The following is a description of a gene set: Mouse Gene Set: GOBP_CELLULAR_RESPONSE_TO_HORMONE_STIMULUS studied in species Mus musculus Any process that results in a change in state or activity of a cell (in terms of movement, secretion, enzyme production, gene expression, etc.) as a result of a hormone stimulus., and this is the list of marker genes: Usp26, Flt1, Crhbp, Sorl1, Hmgcs2, Ghr, Vps54, Appl2, Nodal, Prcp, Ufm1, Lbh, Opa1, Pias2, Ctsh, Pparg (peroxisome proliferator activated receptor gamma), Or51e2, Apc, Anxa5, Gpld1, Scnn1b, Avpr2, Tns2, Pagr1a, Il1b, Cry2, Mettl21c, Mir126a, Pde4d, Max, Kank1, Vdr, Ass1, Cpeb2 (cytoplasmic polyadenylation element binding protein 2), Hras, Pcsk9, Leprotl1, Tfpi, Rxra (NCBI Gene Id 78740), Bmi1, Nucb2, Cyp26b1, Nck1, Slc27a4, Slc2a4, Prkaa1, Kmt2e, Ywhah, Kdm5d, Uso1, Foxh1, Grb14, Rab31 (NCBI Gene Id 67353), Rac1, Anxa1, Zfp592, Rhoa, Ntrk2, Tnfsf4, Dhrs3 (dehydrogenase/reductase 3), Sfrp1 (secreted frizzled-related protein 1), Adcy8, Kdm3a, Abhd2, Nedd4, Sos2, Akr1c19, Nr1d2, Cnot3, Irs2, Scgb2a2, Nr1h2, Flt3, Hnrnpk, Agtr2, Rab8a, Igf1, Epha8, Clock, Fgf23, Ucp1, Mdm2, Mst1r, Gpt, Crh, Mt3, Pck1, Gstp1, Ren1, Ntrk1, Trarg1, Rela, Kbtbd2, Park7, Tcf21, Oxtr (NCBI Gene Id 18430), Mir155, Ar (NCBI Gene Id 11835), Cnot1, Kdm4c, Bglap (bone gamma carboxyglutamate protein), Hcrtr2, Sstr5, Ddit4, Gdf15, Ghsr, Ctnnb1, Adra2a, Lonp1, C2cd5, Csf1r, Rarb, Fgfr2, Mef2c (myocyte enhancer factor 2C), Per1, Nono, Mbd5, Blvra, Calr, Edn1, Naip2, Pik3r3, Ugt1a6a, Nucks1, C1qtnf12, Nr1h3, Cdk2, Rxrg, Sirt1, Epha4, Zfp36l1, Npas4, Kdm6a, Insig2, Bglap2, Fam114a1, Foxo3, Mir18, Fbxw8, Adipor2, Cga, Slc26a6, Akt3, Usf1, Mapk1, Mzb1, Ceacam1, Nfkb1, Ggcx, Aifm1, Zfp106, Phb2, Erfe, Gcg, Ywhag, Rxrb, Thra, Srarp, Rnf6, Cacna1a, Agtrap, Smarcc1, Fshr, Uri1, Rangap1, Atp1a2, Zfp764l1, Leprot, Ffar3, Prlr, Akr1c13, Mstn, Vamp2, Ppargc1a, Erbb2, Rxfp1, Trim24, Rwdd1, Gata4, Hdac9, Prl, Nr5a2, Ramp1, Cfl1, P2ry4, Ptprv, Brca1, Shoc2 (Shoc2, leucine rich repeat scaffold protein), Reg1, Mup4, Map2k1, Prkcd, Gata6, Glp2r, Myod1, Fam107a, Blvrb, Ppp3ca (NCBI Gene Id 99901), Trerf1, Rhoq, Lats2, Cuzd1, Agt, Sorbs1, Ucp3, Echdc3, Agrp, Pou4f2, Ang2, Ctsb, Vps11, Pax8, Foxc2, Sox10, Mir451a, Fer, Got1, Tnf, Nsmf, Notch1, Eef2k, Tyk2, Eif4ebp2, Pik3r1, Ros1, Cyfip1, Hdac6, Il18 (interleukin 18), Smyd3, Nr4a3, Slit3, Arid5a, Mup11 (major urinary protein 11), Ide, Epha2, Sp1, Zbtb7b, Ogt, Ptpra, Lmo3, Ptk2, Sstr1, Syap1 (synapse associated protein 1), Sstr4, Ret, Crhr1, Ramp3, Ctbp2, Aldh1a2, Mir708, Esrra, Slc39a14, Mir148a, Cyp7b1, Rest, Mup5, Fkbp4, Ephb3, Nkx3-1, Gclc, Insr, Prokr2, Serpinf1, Gkap1, Pip4k2b, Sst, Cyp26a1, Ufl1, Mir486, Mirlet7e, Fgfr3 (fibroblast growth factor receptor 3), Casp9, Fgfr4, Ppard, Lep, Socs7 (suppressor of cytokine signaling 7), Asns, Gsk3a, Pde3b, Ncor2, Sgcb, Igf1r, Rbm4, Ostn, Ptpn1, Ins2, Tyro3, Pde3a, Flt4, Adipoq, Kat2b, Ddx17, Pik3r2 (phosphoinositide-3-kinase regulatory subunit 2), Scnn1a, Col6a1, Eif4ebp1, Marcks, Pelp1, Npc1 (NPC intracellular cholesterol transporter 1), Gpr150, Akr1c18, Pdgfra, Mir297-1 (microRNA 297-1), Rbx1, Csk, Esr1, Mfn2, Epha6, Strap, Kank2, Snx5, Sfr1, Axin2, Mir207, Ugcg, Mir493, Rps6kb1, Fbp1, Carm1, Gnas, Stat5b, Raf1, Tbc1d4 (TBC1 domain family, member 4), Mir206, Srebf1, Acsl1, Erbb4, Ufsp2, Mir195a, Rps6kb2, Greb1l, mt-Nd3, Sirt6, Cyp11a1, Ephb4, Pdgfrb, Ncoa2, Mkks, Prkcz, Pdk2, Pck2, Sesn3, Prkaa2, Zmiz1, Cpeb1, Tbx2, Sra1, Bmp4, Heyl, Csrp3, Cyp11b2, Esrrg, Errfi1, Mapkap1, Safb2, Qrfpr, Nr1h4, Tmf1, Ppargc1b, Brip1, Egfr, Prmt2, Mir466 (NCBI Gene Id 723922), Acod1, Fgfr1, Calcoco1, Rdx, Ptprj, Socs3, Map3k7, Gnrhr, Med1, Eprs1, Grk2, Gnai2, Adcy6, Zfp747, Prkd1, Dnai1, Wnt10b, a, Slc30a10, Sh2b2, Zfp536, Rnf14, Aldh1a3, Ppara, Ube3a (NCBI Gene Id 76097), Lpin2, Ifnb1, Gpr173, Prkcb, Vps18, Gclm, Gprin3, Slc9a1, Gjb2, Mir574, Hmga1, Lhcgr, Myo5a, Il17a, Rxfp2, Bdnf, Gria1, Phip, Kmt2d, Pak1, Zfp747l1, Stat3, Mup3, Gpr21, Map1b, Phex, Tbx1, Zfp36, Camk2a (calcium/calmodulin-dependent protein kinase II alpha), Prokr1, Ddx5, Ptges3, Ucp2, Ptprf, Fos, Ptgdr, Sost, Slc27a1, Lncbate10, Nr3c2, Bbs2, Actn2, Ncor1, Adrm1, Epha3, Xbp1, Ocstamp, Sstr3, Akt2, Bcas3, Ncoa5, Pkm, Jak1, Axl, Rarg, Prkca, Inppl1, Fosb, Isl1, Umodl1, Mir21a, Rbfox2, Safb, Brd8, Cul7, Epha1, Ddrgk1, Mir125a, Pim1, Met, Tsc2, Gdnf, Socs2, Capn10, Ncoa3, Esr2, Phb1, Thrb, Ezh2, Lepr, Ephb1, Crhr2, Jak2, Igfbp2, Cps1, Atp5f1a, Padi2, Ccna2, Mup2, Cry1, Crebrf, Mn1, Prkar1a, Snw1, Lats1, Zbtb7a, Grb10, Mtor, Rarres2, Cnot9, Gper1, Rab10, Bbs4, Trh, Parp1, Fech (NCBI Gene Id 14151), Cldn18, Tshr, Akap8, Atp2b1, P2ry6 (NCBI Gene Id 66545), Mir125b-1, Epha5, Ptf1a (NCBI Gene Id 54333), Ccl2, Src, Ncl, Igf2, Ghrhr, Tnc, Nr2c1, Stat6, Tgfb1, Ptger2, Foxa1, Daxx, Avpr1b, Grb7, Zfp366, Akr1c12, Nr0b1, Ptpn2, Ramp2, Fut7, Ins1, Gpam, Glp1r, Eif4e, Gja1, Epha10, Gphb5, Inhbb, Pklr, Epha7, Trim68, Sos1, Rab13, Nr4a2, Crkl, Gsk3b, Lpin1, Wdtc1, Dab2, Cul3, Ror2, Plcb1, Abcb1a, Klf9, Mapk3, Lpl, Npffr2, Alk, Inpp5k, Mir494, Uchl3, Dnaaf4, Prkci, Agtr1a, Trip4, Ptger4, Ncoa1, Zdhhc7, Akt1, Cckar, Ucn2, Rb1, Crk, Dnaja1, Gcgr, Esrrb, Hnrnpu, Ddr1, Ceacam2 (CEA cell adhesion molecule 2), Ltk, Cyp11b1, Slc2a8, Enpp1, Sgk1, Nr5a1, Shq1, Actn4, Fbxo32, Hcrtr1, Naip6, Ubr5, Pten, Bcar1, Ube2l3, Star (NCBI Gene Id 52131), Ppp5c (NCBI Gene Id 19060), Scnn1g (NCBI Gene Id 20278), Aqp1, Dennd4c, Tie1, Prkdc, Nkx6-1, Sva, Lancl2, Akap13, Adipor1, Mir146, Srsf3, Klf2, Stat5a, Ndel1, Slc25a33, Mir672, Zfp36l2, Tgif1, H2az1, Csnk2b, Trp63, Sik2, Nfe2l2, Hsf1, Mir223, Jak3, Sco1, Pip4k2a, Igfbp1 (NCBI Gene Id 210369), Pid1, Obp2a, Kit, Inhba, Rap1gds1, Atp1a1, Mir145a, Qrfprl, Vwa2, Lpin3, Irs3, Foxo1, Fgb, Rock2, Zfp764, Foxo4, Ugt1a6b, Nr3c1, Ddr2, Acaca, Arid1a, Ptpn11, Wnt1, Naip1, Ahcyl1, Musk, Cav1, Ncf2, Serpina12 (NCBI Gene Id 68054), Gck, Ugt1a1, Mas1 (NCBI Gene Id 17171), Mtcl2, Acbd7, Pxn, Socs1, Pdk4, Trib3, Mgarp, Stxbp4, Insig1, Bcar3, Trim63, Trim72, Rara, Rock1, Fbn1, Ptgfr, Pax6, Irs1, Tek, Itgb3, Ctsd, Gata1, Pip4k2c, Mertk, Otop1, Gh, Ahsg, Taf7, Uba5, Pgr, Irf1, Sstr2, Ucn3, Pik3ca, Agtr1b, Cyp1b1, Npffr1, Cyp27b1 (cytochrome P450, family 27, subfamily b, polypeptide 1), Ptpre, Ednra, Insrr, Ep300, Cnot2, Skp2, Strn3, Smarca4, Mup1, Cav2, Bglap3, Stc1, Nr1d1, Ace, Wt1, Hdac1, Pdpk1, Pml, Adcyap1, Asxl1, Bmal1, Ntrk3, Gpr22, Appl1, C1qtnf9, Myo1c, Hmga2, Foxp1, Irs4, Prkcq, Ankrd26, Nr4a1, Mir142, Prkce, Shc1, Grb2, Snai2, Wbp2, Ephb2, Avpr1a, A1bg, Car2, Prkaca, Kdr, Mir143 (NCBI Gene Id 387161), Osbpl8, Efna5, Etnppl, Cst11